Given this list of marker genes PPP3CB, PKN3, PKN2, GNAQ, PRKD2, PPP3CC, PKN1, PRKCA (NCBI Gene Id 5578), PRKCB, RCAN1, PRKCQ (protein kinase C theta), PRKCI, PRKCG, PRKCH, PPP3R2, PPP3CA, PRKD3, PRKCZ, PPP3R1, NFATC1, ANGPT2, PLCB3, PRKD1, PRKCD, PRKCE, here is a description of the gene set: species: Homo sapiens GNAQ p.R183Q drives capillary malformation Human Gene Set: WP_GNAQ_PR183Q_DRIVES_CAPILLARY_MALFORMATION